The following is a description of a gene set: studied in species Homo sapiens Human Gene Set: HP_PATCHY_ALOPECIA Patchy alopecia Transient, non-scarring hair loss and preservation of the hair follicle located in in well-defined patches., and this is the list of marker genes: TRAC, LMNA, DSG4, HRAS, PORCN, AIRE, KDM5C, IKBKG, KCTD1, ZMPSTE24, COL17A1, KRT81, ITGB4, ECM1, KRT86, EBP, EXOSC2, TP63, NECTIN4, ASL, TGM3, LAMB3, HR, IL2RA, KRT83, PADI3, BLM